Given this list of marker genes Ppm1b, Fam83h, Scn2b, 4930544G11Rik, Mta2 (NCBI Gene Id 23942), Notch1, Foxj2, Met (NCBI Gene Id 194383), Dcaf7, Mtcl2, Gabra3, Fut8, Vwa5b2, Vat1, Tmed8, Rfx3, Tmem45a2, Dgkz, Ccne2, 9930012K11Rik, Usf1, Erc1, Galnt7, Mycn, Slc4a7, Zfp120, Mgat4a, Mdm4, Numbl, Arid4b (NCBI Gene Id 94246), Slc6a1, Pdgfra, Etl4, Nat8l (N-acetyltransferase 8-like), Srpra, Sirt1, Metap1, Lyplal1, Arhgap26, Polq, Ppargc1b, Rhoh, Asic2, Ltbp2, Vamp2, Dcx, Tmem164, Car7, Lef1, Il6ra, Ppfia1, Scamp4, Strn3, Gmfb, Creb3l2, Slc25a53, Slc25a27, Snx15, Ldha, Gpr158, Pacs1, Syt1, Osgin2, Coro1c, Add2, Pkp4, E2f5, Fam107a, Daam1 (NCBI Gene Id 69600), Camta1, Foxn2, Nav1, Vcl, Plcb1, Itch, Hcn3, Ubl4a, Nectin1, Lman1, Nos1, Zkscan16, Krtap16-1, Sidt2, Celf3, Mpp2, Rab21, Zfp282, Hspb6, Mmab, Tent5a, Kcna6, Tnrc6b, Abr, Golph3l, Serpinf2, Tgif2, Ing5, Mmp25, Dgkb (NCBI Gene Id 217480), Ttc19, Slc44a2, Atg4b, Htr2c, Tmem79, Ergic1, Scml2, Cbfa2t3, Gpr165, Gmnc (geminin coiled-coil domain containing), Rps6ka4, Acsl1, Eml5 (NCBI Gene Id 319670, echinoderm microtubule associated protein like 5), Fam76a, Lhx2, Snx12, Brpf3, Satb2, Mllt3, Mex3c, Ucn2, Calcb (calcitonin-related polypeptide, beta), Patz1, Frk, Taf5, Dpysl4, Ddx17, Jade2, Ccdc85a, Cacna2d2, Rmnd5a, Rragc, Svop, Tom1, Ppp2r3a (protein phosphatase 2, regulatory subunit B'', alpha), Wscd2, Bnc2, Pogz, Abcd1, Lgr4, Pnoc, Rtn4rl1, Erp44, Synj1, Thtpa, Arhgap1, Pip4p2, Zdhhc16, Notch2, Zmym4, Lman2l, Pitpnc1, Cuedc1, Lzts3, Pip5k1a, Tanc2, Fut9, Gpr22, Zfp281, Tppp, Shkbp1 (NCBI Gene Id 192192), Ahcyl2, Ppp1r11 (NCBI Gene Id 76497), Rtl4, Tbc1d2b (NCBI Gene Id 67016), Acsl4, Kitl, Ankrd52, Cntn2, Map2k1, Nrip3, Thumpd1, Dixdc1, Vdr, Csf1r, Fbxo30, Tmem255a, Azin2, Akap6 (A kinase anchor protein 6), Slc4a8 (NCBI Gene Id 59033), Zfp644, Atp2b4, Trank1, Calcr, Unc13c, Rras, Hexa, Ago4, Nav3, E2f3, Chd1, Tbl1xr1, Casp2, here is a description of the gene set: Mouse Gene Set: MIR_34B_5P Genes predicted to be targets of miRBase v22 microRNA mmu_miR_34b_5p in miRDB v6.0 with MirTarget v4 prediction scores > 80 (high confidence targets). studied in species Mus musculus from publication Chen Y, Wang X (PMID 31504780)